Given this list of marker genes Tcf7, Tcf7l2 (transcription factor 7 like 2, T cell specific, HMG box), Tcf7l1, here is a description of the gene set: species: Mus musculus This event has been computationally inferred from an event that has been demonstrated in another species.<p>The inference is based on the homology mapping from PANTHER. Briefly, reactions for which all involved PhysicalEntities (in input, output and catalyst) have a mapped orthologue/paralogue (for complexes at least 75% of components must have a mapping) are inferred to the other species. electronically inferred by orthology from the curated human pathway Reactome Pathway: Repression of WNT target genes part of: Degradation of beta-catenin by the destruction complex